Given this list of marker genes DDRGK1, IL2, IL10, XBP1, CR1, BCL6, here is a description of the gene set: Human Gene Set: GOBP_REGULATION_OF_PLASMA_CELL_DIFFERENTIATION Any process that modulates the frequency, rate or extent of plasma cell differentiation. studied in species Homo sapiens